The following is a description of a gene set: The enzymatic release of energy from inorganic and organic compounds (especially carbohydrates and fats) which either requires oxygen (aerobic respiration) or does not (anaerobic respiration). studied in species Mus musculus Mouse Gene Set: GOBP_CELLULAR_RESPIRATION, and this is the list of marker genes: Ndufa12, Mdh1 (NCBI Gene Id 83566), Trpv4, Cox7c, Antkmt, Ndp, Col6a1, Ndufb11, Sdhb, Mtfr1l, Uqcrb, Ndufa10, Cox6a1, Pde2a, Ppargc1a, Macroh2a1, Ndufs3, Snca, Atp5me (ATP synthase membrane subunit e), Sdhaf2, Sod2, Mup11, Rhoa, Oas1e, Ifnar1, Ndufa2, Prelid1, Bdnf, Nipsnap2, Suclg1, Etfa, Ndufab1, Cox8b, Ndufv1, Bcl2l13, Dlst, Ndufs2, Pm20d1, Dnajc15, Oas1h, Atp6-ps, Ndufb3, Ndufb4, Uqcrh, Mdh2, Cycs, Ccnb1, Ndufaf1 (NADH:ubiquinone oxidoreductase complex assembly factor 1), Afg1l, Mup4, mt-Co3, Adsl, Uqcc2, mt-Co1, Oas1b (2'-5' oligoadenylate synthetase 1B), Nfatc3, Mtch2, Ndufb6, Idh3b (NCBI Gene Id 96966), Jmjd8, Ak4, Il4, Ndufc1, Cisd1, Uqcrc1, Ifng, Cox7a1, Nr4a3, Sdha, Etfdh, mt-Nd6, Ndufv3, Chchd5, Dnajc30, Bid, Sirt3, Uqcrq, Uqcrc2 (ubiquinol cytochrome c reductase core protein 2), Cdk1, Mybbp1a, Mlxipl, Ndufa1, Mtfr1, Atp5f1b, Mup3, Atp7a (NCBI Gene Id 51824), Ndufs1, Mup2, Ndufa3, Sdhd, Sco2, Mup1, Pnpt1, Oas1g, Uqcc3, mt-Nd4l (mitochondrially encoded NADH dehydrogenase 4L), Mir451a, Abcd1, Ucn, Cbfa2t3, Atp5if1, Akt1, Il10rb, mt-Nd3, Hoxb3os, mt-Nd5, Etfrf1, Cat, Idh3a, Pik3ca, Ndufa6, Opn3, mt-Atp8, 1700066M21Rik, Trex1, Ndufb8, Ndufa5, Slc25a33, mt-Nd2, Cox5a, Ppif, Cox6b1, Oas1c, Immp2l, Arl2, Pank2, Ndufb7, mt-Nd1, Lyrm7, Atp5mf, Cox7b, Aifm2, Mir451b, Atp5pd, Ndufa7, Ndufs7, Ndufa8, Coq9, Mtln (NCBI Gene Id 67885), Slc25a51, Tefm, Cox8c, Atp5pb, Shmt2 (NCBI Gene Id 72410), Cox7b2, Tnf, Ndufs6, Prdm16, Ndufb9, Pdhb, Uqcr11, Plec (NCBI Gene Id 381012), Mtfr2, Cs, Ndufs4, Cyp1a2, Atp5pf, Dld, Coq10b, Chchd10, Apoc3, mt-Cytb, Actn3, Ndufb1, Ccnb1-ps, Gba1, Chchd4, Chchd2-ps, Uqcrfs1, Pdha2, Fxn, Ndufa11, Atp5f1a, Myog, Atpsckmt, Oas1f, Oas1d, Oxa1l, Ndufa9, Aifm1, Atp5f1c, Fh1, Ndufc2, Pum2, mt-Atp6, Aco1, Cox7a2l, Vps54, Mdh1b, Sdhaf4, Ndufb10, Ndufs5, Nupr1, Ndufb2, Idh1, mt-Nd4, Ogdh, Tafazzin, Slc25a23, Nop53, Cyct, Ifnlr1, Ndufb5, Bax, Cox5b, Slc25a25, Coq7, Coa6, Vcp, Stoml2, Ndufv2 (NADH:ubiquinone oxidoreductase core subunit V2), Etfb, Ndufa13, Slc25a13, Iscu, Atp5f1e, Park7, Aco2, Norad, Chchd2, Msh2, Nfatc4, Cox7a2, Tmem135, Trap1, Sdhc, Ide, Oas1a, Cox8a, Cox6a2, Dguok, Cyc1, Uqcr10 (ubiquinol-cytochrome c reductase, complex III subunit X), Dlat, Cox4i1, Mup5, Abcc9, Prkaca, Ndufs8, Atp5po, mt-Co2, Ogdhl, 4933405O20Rik, Cox6c, Pdha1, Bloc1s1, Myc, Mrps36 (NCBI Gene Id 66128), Mfn2 (mitofusin 2), Idh2, Mfsd8, Atp5f1d, Cox4i2, Cox10, Csl, Suclg2, Pink1, Sucla2, Cox6b2, Idh3g